Given this list of marker genes COMT, SNAP25, SLC35A3, YWHAE (tyrosine 3-monooxygenase/tryptophan 5-monooxygenase activation protein epsilon, NCBI Gene Id 7531), ATP6V1A, COL6A2, LTBP1, COL3A1, LARGE1, FHL1, ATP6V0A2, EXT1, COL2A1 (NCBI Gene Id 444981), SEC24C, GTF2I, GDF5, SSR4, KLHL41, USP9X, CHAT, POMT2, FGF8, ARFGEF2, ERCC1, BRIP1, TNFRSF11B, NIPBL, NAA10, IFT56, BRCA1, CHST3, EBF3, GCDH, DSE, FBLN5, B3GALT6, MKKS, SMO, GJA1, FANCB, AHDC1, C1R, FKBP6, ASXL1, EXOSC3, SLC5A7, HGD, LMNA, LETM1, GLRA1, CPLX1 (NCBI Gene Id 10815), CLCN7 (NCBI Gene Id 7814), SLC12A2, FANCA, GTF2IRD1, AGRN, PLOD1, GPC3, FGFR1 (NCBI Gene Id 84151), UBE2A, CD96, CANT1 (calcium activated nucleotidase 1), ALG9 (NCBI Gene Id 79796), SYNE1, DHCR7 (NCBI Gene Id 6589), MAP3K7, CHRNG, ERGIC1, CREBBP, AEBP1, HK1, C1S, EFEMP2, DVL3, IFITM5, PYCR1, SLC18A3, FANCF, COLEC11 (collectin subfamily member 11), STXBP1, ADAMTS2, PIK3CA, COL6A3, GZF1, GTF2H5, FANCM, IPO8, TGIF1, SALL4, KANSL1, FGFRL1, TNNT3, TONSL, NLRP3, SLC35B2, DNASE1L3, ZC4H2, SLC6A9, BMP1, EIF2AK3, CSGALNACT1, SMC3, LYSET, RFC2, CTBP1, BUD23, EXTL3, TOR1A (torsin family 1 member A), FOXH1 (forkhead box H1), PTRH2, SKI, GNB2, EIF4A3, TPM3, DLL1, MYH8, GSC, EP300, C12orf57, GLI3, MCTP2, CDC6, SELENON, IARS2, SCARF2, NAE1, WNT5A, RBM8A, XYLT1, CEP85L, SF3B4, TGFBR2, SEC31A, COL12A1, OBSL1, YY1, NXN, RFWD3, KDM6A, FANCI, RAD51, FANCL, FANCC, COL27A1, CHRNA1 (cholinergic receptor nicotinic alpha 1 subunit), AKT1, AARS1, COL5A2, SMAD2, POLR3B, ARF1, WNK3, BGN, BRD4, ARNT2, ORC6, COL13A1, FBN1, ZMPSTE24, FANCG, UFD1, LRP4, LIMK1, PRKACB, SIX1, ATP7A, TRPS1, SPARC, DPYSL5, FIG4, LMOD3, CHST14, GMNN, SNRPB, LRP1, TBL2, NOG, BPNT2, RNU4ATAC, RNF113A, HACE1, EBP, FLNB, FLI1, RECQL4, UBE2T, FANCD2, DONSON, FLNA, ORC1, NOTCH2, BRCA2, TBX5, SCYL2, GPC4, SMARCA2, PIEZO2, SMC1A, ZNF469, HPRT1, UBA2, GP1BB, PRKAR1A, OSGEP, UBE3B, BAZ1B, TBX1, GLI2, ARID1B, COL1A2, MYL2, NEB, THBS2, ADAMTSL2, ECEL1, ZIC3, KIF22, MAP1B, MAD2L2, EYA1, CCDC8, CLTCL1, CDC45, PLCH1, GLRB, HIRA, TARS1, ERMARD, ATAD1, TBCD, XRCC2, PUF60, CFL2, HOXA11, SHROOM4, TRIM8, VAC14, GMPPB, THRA, ANKH, ARVCF, CCDC47, METTL27, RUNX2, CLIP2, JMJD1C, GPHN, GPC6, DVL1, OCRL, L1CAM, GAS1, PIGL, ERCC2, ELN, SLC10A7, NKX3-2, EXOC6B, TAF6, ERCC4, SRCAP, SHOX, MAB21L2 (mab-21 like 2), DNAJC30, HACD1 (3-hydroxyacyl-CoA dehydratase 1), SMOC1, TGFBR1, SHH, GORAB, PDE4D, MYO9A, TGFB2, TBX15, SLC26A2, CHRM3, PAFAH1B1, CHRND, STIL, CDON, NODAL, SLC6A5, CRIPTO, TMTC3, RAD51C, ZFX, CLCN3, PKDCC, GNPTAB, GTF2IRD2, POMT1, MBTPS2, SLC2A10, LMX1B, SIL1, COLEC10, WNT7A, STX1A (NCBI Gene Id 6804), MAFB, DNAJC21, FBXL3, MACROH2A1, TMEM270, FBLN1, PORCN, COL5A1, MASP1, HSPG2 (NCBI Gene Id 7796), STAG2, DHODH, COL25A1, ROR2, CUL7, DISP1, KMT2D, BMP4, NGLY1, ATP6V1E1, SLX4, TGDS, TFE3, FKRP, FUT8, TELO2, HDAC8, LBR (NCBI Gene Id 653311), MACF1, ABCC9 (NCBI Gene Id 102724274), LONP1, RAD21 (NCBI Gene Id 5885), DSTYK, COL6A1, BICD2, IFIH1, VPS37D, VAMP1, SLC25A1, SMAD3, TCTN3, COX8A, ZIC2, TBX4, TGFB3, PPP2R5D, SLC39A13, NCF1, MYH3, NEDD4L, HDAC4, B3GAT3, ERI1, ALDH18A1, SIX3, PALB2, CHST11, ATR, MAP3K20, VDR, TPM2, RYR3, COL1A1, PTCH1, SYT2, FANCE, HNRNPH1, CDT1, RYR1 (ryanodine receptor 1), PITX1, NSD2, RREB1, ITGA7, FBN2, IL6ST, ORC4, KAT6B, ERCC3, GEMIN4, CARS1, FZD2, APC, NFIX, PHLDB1, NSDHL, EIF4H, B4GALT7, ACTA1, MPLKIP, PYCR2, SOX9, AFF3, GTF2E2, here is a description of the gene set: Human Gene Set: HP_JOINT_DISLOCATION Displacement or malalignment of joints. Joint dislocation studied in species Homo sapiens